The following is a description of a gene set: Cytokines mediate cell-cell communication in the immune system and represent important therapeutic targets. A myriad of studies have highlighted their central role in immune function, yet we lack a global view of the cellular responses of each immune cell type to each cytokine. To address this gap, the authors created the Immune Dictionary, a compendium of single-cell transcriptomic profiles of more than 17 immune cell types in response to each of 86 cytokines (>1,400 cytokine-cell type combinations) in mouse lymph nodes in vivo. A cytokine-centric view of the dictionary revealed that most cytokines induce highly cell-type-specific responses. For example, the inflammatory cytokine interleukin-1β induces distinct gene programmes in almost every cell type. A cell-type-centric view of the dictionary identified more than 66 cytokine-driven cellular polarization states across immune cell types, including previously uncharacterized states such as an interleukin-18-induced polyfunctional natural killer cell state. Genes negatively differentially expressed in cell type: cDC1 (conventional dendritic cell type 1) upon treatment with cytokine: IL-18 in mouse lymph nodes in vivo. from publication Cui A, Huang T, Li S, Ma A, Pérez JL, Sander C, Keskin DB, Wu CJ, Fraenkel E, Hacohen N (PMID 38057668) species: Mus musculus Mouse Gene Set: CUI_CDC1_IL18_RESPONSE_DN, and this is the list of marker genes: Rab32, Syne1, Rtl8b, Itgb7, Inpp5d, Acss1, Rab11fip1, Tubb2a, Mxd4, BC028528 (NCBI Gene Id 229600), Sh2d3c, Lipa, Sgk1, Higd2a, Eif3f, Cd37, Commd8, Alox5ap, Zfp36l1, Ccr2, Pdcd4, Man2b1, Ypel3, Slc66a2, Gdi2, Fau (FAU ubiquitin like and ribosomal protein S30 fusion), Polr1a, Camk1d, Ppfia4, Nsa2, Pglyrp1, Dusp1, Cd81, Ctsh, Tlr12, Shtn1, Niban1, Unc93b1, Gpr68, Fosb (FBJ osteosarcoma oncogene B), Gpx1, Ahnak (AHNAK nucleoprotein), Treml4 (NCBI Gene Id 75989), Cytip, Lbh, Ctdp1 (NCBI Gene Id 67655), Nadk (NCBI Gene Id 70777), Creg1, Ppt2, Ivns1abp, Uba52, Unc119b, Fnbp1, Pold4, Tm2d2, Unc119, St3gal5 (NCBI Gene Id 20454), Pmaip1, Rgs2, Rnd3 (Rho family GTPase 3), Klf4, Npm1, Mef2c, Hepacam2, Tsc22d3, Laptm5 (NCBI Gene Id 16792), Clk1, Btg2, Septin6, P3h2 (prolyl 3-hydroxylase 2), Siglecg, Erp29, Ndufa6, Rab7b, Ptpn18, Fmnl1, Rassf5, Klhl6, Sdf2, Il6ra, Igsf6, Uvrag, Smpdl3a, Tnrc6b, Ubb, H1f2, Tnfaip8, Aph1c, Xpr1 (xenotropic and polytropic retrovirus receptor 1), Jun, Nr4a1, Borcs6, Otulinl, Rtl8a, Lyz2, Adrb2, Pbxip1, Myo1f, Polr1d, Itm2b, Rgs10, Dpp4, Proser2, Fos, Tm6sf1, Bri3bp, Prcp, Nr4a2, Tbl1xr1, Cd300c2, Arsb, Eef2, Klhl24, Cox7a2l, Kctd12, Ramp1, Glul, Klf2, Gpr65, Cerk, Ighm, Zfp36l2, Cat, Imp3, Arhgap18, Npc2, Arhgap45 (Rho GTPase activating protein 45), Slc25a20, Ifngr1, Gpsm3, Mapk14 (NCBI Gene Id 26416), Lrrc25, Ankrd44, Kctd14, Lpin1, Nop53, Pid1, Rsrp1, Clec12a, Rp9, Cd244a, Pld4, Bnip3l, Atp5mc2, Gm2a, Ucp2, Cxcr3, Tyrobp, Itpripl1